Given this list of marker genes ITGAX, ITGB2, ITGB5, TNC, ITGA3, ITGAL, ITGAV, ITGAE, ITGA5, ITGA2, CD47 (CD47 molecule), ITGB3, ITGAM, here is a description of the gene set: Human Gene Set: MODULE_412 Genes in the cancer module 412. studied in species Homo sapiens